Given this list of marker genes FGF1, PTPN11, FGF16, PIK3R1, FGF20, FRS2, FGF6 (fibroblast growth factor 6), FGF23, FGF19, KLB, FGF2, FGF17, FGF8, FGF18, GAB1, FGF4, FGFR4, FGF9, PIK3CA, GRB2, here is a description of the gene set: studied in species Homo sapiens Human Gene Set: REACTOME_PI_3K_CASCADE_FGFR4 PI-3K cascade:FGFR4